Given this list of marker genes GRAP2, SVIL, NIBAN3, IL10RB, GNE, DAXX, BCAS3, CEACAM21, ZNF775, VPS39, RAB3D, FOXO3, TCTA, FOXP1, TLR7, LY6E, ARID5B (AT-rich interaction domain 5B), TMEM140, PRSS12, TLR2, RFTN2, ITGB7, SLC66A2, SDC1, FBXL4, TXNDC15, TBCCD1, BBS4, TSGA10, NOP53, TRIM8, FBXO32, KDM5B, ZDHHC14, P2RX4, GFI1, LPAR6, TIPARP, MYL12B, COPG2, TET2, RAB24, DPP4, PIP4P2, SPNS2, CCR7, ZNF281, PCID2, AFP, NRROS, SEMA4B, WLS, RFLNB, HLA-E, PTPN12, MYLIP, B3GNT5 (UDP-GlcNAc:betaGal beta-1,3-N-acetylglucosaminyltransferase 5), GAD1, RBAK, SNX5, CIR1 (corepressor interacting with RBPJ, CIR1), DOP1B, GPR180, ZDHHC13, CD81, GDPGP1, IL10RA, IRGM, DDX18, HCK, TREML2, S100A10, CREB3L2, CHD2, RIPOR2, RNF146, MYO7A, EEF2K, RDH14, C3orf33, RAP2B, MCCC1, KIAA0040, MAP2K4, UBR3, RCAN1, RTP4, TMED3, ZNF274, POGLUT2, CREBRF, ZMYND11, SNRK, L3MBTL3, P4HA1, KLC4, SOCS3, MGST1, ALDH2, ABHD11, CCPG1, RABAC1, CD1D, SERINC1, ACP6, SLC10A3, ARHGAP24, ADAM19, GGH, PLBD1, ABHD17B, ERRFI1, ST8SIA4, UBL3, IQGAP2, RASGRP2, ARSK, FEZ2, SPATA6, CACFD1, FRMD6, SPATA13, PRKCI, FCRL1, TCN2, ACADVL, SOCS5, ADD1, TMOD3, CEBPZ, SDC4, GORASP2, GIMAP4, NUCB2, DTD1, DSTYK, MBTPS1, B4GALNT1 (NCBI Gene Id 550623), AFF3, ANXA6, USP3, AGL, NFKBIA, ZC3H10, FAM43A, SLC25A37, ZFP36, CRY1, ZBTB10, ARL4A, MYO1H, DBT, SBK1, ADGRE1, KMO, MTMR10, GIMAP8, LPCAT2, GOLM1, CA2, STK24, KCTD14, CAPG, CDC42SE1, ATP10D, IFNAR2, CD38, RSRP1, ARHGAP9, IVD, GPR174, MAN1A1, PDIA4, SPECC1L, TAFAZZIN, PXDC1, CLN5, MAP3K1, PRXL2A, TTC28, MFHAS1, TDRD7, CYRIA, LPCAT1, FCGRT, RNF13, MTAP, HIBADH, ACSS2, LRATD2, SAT1, ZNF394, TYROBP, ACOT2, TRIM25, SUFU, CYTH3, KLHL22, PLA2G15, CHD3, here is a description of the gene set: Genes up-regulated in CD4 T conv over-expressing: FOXP3 versus IKZF4 and FOXP3. The transcription factor FoxP3 partakes dominantly in the specification and function of FoxP3+ CD4+ T regulatory cells (Tregs), but is neither strictly necessary nor sufficient to determine the characteristic Treg transcriptional signature. Computational network inference and experimental testing assessed the contribution of several other transcription factors (TFs). Enforced expression of Helios or Xbp1 elicited specific signatures, but Eos, Irf4, Satb1, Lef1 and Gata1 elicited exactly the same outcome, synergizing with FoxP3 to activate most of the Treg signature, including key TFs, and enhancing FoxP3 occupancy at its genomic targets. Conversely, the Treg signature was robust to inactivation of any single cofactor. A redundant genetic switch thus locks-in the Treg phenotype, a model which accounts for several aspects of Treg physiology, differentiation and stability. species: Homo sapiens from publication Fu W, Ergun A, Lu T, Hill JA, Haxhinasto S, Fassett MS, Gazit R, Adoro S, Glimcher L, Chan S, Kastner P, Rossi D, Collins JJ, Mathis D, Benoist C (PMID 22961053) Human Gene Set: GSE40274_FOXP3_VS_FOXP3_AND_EOS_TRANSDUCED_ACTIVATED_CD4_TCELL_UP